Given this list of marker genes Zfp94, Klf11, AI597479, Tenm3, Gpr161, Mbd2, Grid1, Mlst8, Atp6v1a, Sowaha (NCBI Gene Id 237761), Stx5a, Chd9, Chn1, Defb6, Defb4, Smc3, Or7d10, Uchl5, Pvr, Meioc, Yipf5, Ctnna3, Plau, Bcas1, here is a description of the gene set: Mouse Gene Set: MIR_5128 species: Mus musculus from publication Chen Y, Wang X (PMID 31504780) Genes predicted to be targets of miRBase v22 microRNA mmu_miR_5128 in miRDB v6.0 with MirTarget v4 prediction scores > 80 (high confidence targets).